The following is a description of a gene set: Human Gene Set: LEE_LIVER_CANCER_MYC_E2F1_UP Genetically modified mice have been extensively used for analyzing the molecular events that occur during tumor development. In many, if not all, cases, however, it is uncertain to what extent the mouse models reproduce features observed in the corresponding human conditions. This is due largely to lack of precise methods for direct and comprehensive comparison at the molecular level of the mouse and human tumors. Here we use global gene expression patterns of 68 hepatocellular carcinomas (HCCs) from seven different mouse models and 91 human HCCs from predefined subclasses to obtain direct comparison of the molecular features of mouse and human HCCs. Gene expression patterns in HCCs from Myc, E2f1 and Myc E2f1 transgenic mice were most similar to those of the better survival group of human HCCs, whereas the expression patterns in HCCs from Myc Tgfa transgenic mice and in diethylnitrosamine-induced mouse HCCs were most similar to those of the poorer survival group of human HCCs. Gene expression patterns in HCCs from Acox1(-/-) mice and in ciprofibrate-induced HCCs were least similar to those observed in human HCCs. We conclude that our approach can effectively identify appropriate mouse models to study human cancers. Genes up-regulated in hepatocellular carcinoma (HCC) from MYC and E2F1 double transgenic mice. from publication Lee JS, Chu IS, Mikaelyan A, Calvisi DF, Heo J, Reddy JK, Thorgeirsson SS (PMID 15565109) studied in species Homo sapiens, and this is the list of marker genes: CTSS, CISH, RAD51B, GPC3, CXCL9, IFIT2, FABP4, ANXA2, KRT8, SMC4, CD74, DEFB1, LPL, CSTB, ACTG1, USP18, VIL1, SPINK1, CDK1, LY6E, TPR, COL1A2, TAGLN2, ICAM1, KIF20A, LAMA5, IFI44, MAD2L1, UNC13B, PALMD, HLA-DQA1, SPARC, FMO3, TMEM176B, SPP1, UAP1L1, PLAT, LCN2, NUCB2, SLC13A3, CYP39A1, SLC1A4, PPL, CD63, ROCK1, COL1A1, ANXA5, MMP12, IGFBP1, PTGDS, LY6D, CD72, PLSCR1, BCL2A1, NUSAP1, SPTAN1